The following is a description of a gene set: studied in species Mus musculus Mouse Gene Set: GOMF_17_BETA_HYDROXYSTEROID_DEHYDROGENASE_NADPPLUS_ACTIVITY Catalysis of the reaction: a 17-beta-hydroxysteroid + NADP+ = a 17-oxosteroid + NADPH + H+., and this is the list of marker genes: Hsd17b6, Dhrs11, Akr1c21, Hsd17b14, Dhrs1, Akr1c6, Akr1c20, Hsd17b3, Hsd17b1 (hydroxysteroid (17-beta) dehydrogenase 1)